The following is a description of a gene set: Mouse Gene Set: chr1D studied in species Mus musculus, and this is the list of marker genes: Pdcd1, Gm29461, Gm18699, Col6a3, Gm7952, Slco6b1, B230216N24Rik, Gpr35, Per2, Capn10, Snorc, Gm23434, Iqca1 (NCBI Gene Id 75891), Ankmy1, Ugt1a1, Sh3bp4, Glrp1, Gm17415, Or9s27, Atg16l1, 1700020N18Rik, Dtymk, Btf3-ps1, 4930434B07Rik, Or9s23, Ndufa10, Gm7889, Or9s14, Cops9, St8sia4, Gm7895, Gm6430, Gm26078, Kif1a, Traf3ip1, C030007H22Rik, Crocc2, Hjurp, Gm7967, Neu4 (sialidase 4), Mir6345, Gm10550, Gm6153, Gm9991, 5033417F24Rik, Gm18697, Pask, 4833421G17Rik, Cops8, Gm15374, Gm26446, Gal3st2b, Gm29601, Gm15375 (NCBI Gene Id 677561), Gm7785, Pam, Gm15371, Usp40, Gal3st2, Gbx2, Gm28499, Dusp28, Asb18, Gm15368, Gm7776, Dgkd, Asb1, Mir6900, Ugt1a9, Gm7867, Gm5264, Scly, 1700063A18Rik, Gm7891, Atg4b, Slco4c1, 1700067G17Rik, Gm15376, Gm28382, Rab17, Agap1, 9430060I03Rik, 4930440C22Rik, Gm25395, Ube2f, Gpc1, BC055308, Espnl, Ramp1, Erfe, Gm15372, Gm28722, Ano7, Twist2, Gm5259, Gm23389, Septin2, Agxt, Gm1833, Gm29483, Gm28535, Panct2, Spp2, D130058E05Rik, Thap4, Sag, Ugt1a7c, Hdac4, Aqp12, Sned1, Ilkap, Gm23181, Slco6d1, Gm19582, Mir149, D2hgdh, Mir6901, Or6b2b, Ugt1a5, 4930474B08Rik, Mroh2a, Ngef, Gm35048, Gm29337, Or6b2, Trpm8, Gal3st2c, Gm18666, Mterf4, Gm18248, 4930453O03Rik, Hdlbp, Ugt1a8, 1810006J02Rik, Gm7837, Gm28380, Or9s15, Mlph, 4930533P14Rik, Ackr3, Gm15427, Bok, Rnpepl1, Prlh, Ugt1a2, Ugt1a6b, Gm22089, Mab21l4, Gm19589, Inpp5d, Mir6902, Gm7135 (predicted gene 7135), 1700054K02Rik (NCBI Gene Id 78350), Ppip5k2, Ugt1a10, Gm19085, 4933400F21Rik, Gm5832, Gm7133 (predicted gene 7133), Hes6, Rbm44, Ing5, Slco6c1, Scarna6, Fam174a, Platr5, Gm3555, Or9s13, Gm29481, Klhl30, Gm29538, Ugt1a6a, Macir, Arl4c, Gm4753, Otos, Gm29480, Gm28888, Dnajb3 (DnaJ heat shock protein family (Hsp40) member B3), Gin1, Neu2 (NCBI Gene Id 23956), 4930598F16Rik, Farp2, Lrrfip1, Stk25, Ppp1r7, Or6b3, Gm9499